Given this list of marker genes SERPINH1, PSAPL1, ANGPT2, UPP1, KRT15, MVK, STMN3, C1QBP, DOK2, GNGT2, FGF12, TGFB3 (NCBI Gene Id 7043), FBXO21, FOXA3, SYNPO, NCAPH2, LIPC, DEF8, GPR137B, RNF19B, ZBTB14, SAP30, A2M, DCK (deoxycytidine kinase), FEZ1, ATF6, SGO1, IMP4 (NCBI Gene Id 92856), PDZK1, DBT, RAB23, EVL, SYNE4, NR4A2, PSMD3, CD52, IKZF1, ADSS1, NOS2, SORD (sorbitol dehydrogenase), DNMT3A, DAGLB, UNC50, CSF3, RAD23B, GNL1, MELTF, PRRC1, TBRG4, IRF7, MRPS18B, CEP89, GSG1, PGD, KRT20, H2BC5, GALNT2, PPP2R5A, PDIA3, RRP1B, CIPC, KAT7, RBL1, MMP16, CYTIP, LIPE, TNFRSF11B, ELAC2, MORF4L2, ARPP19, EYA2, IKBKE, MTOR, CTSE, FOLR2, KCNA4, FCGR1A, WT1, CNGA1, PTGER1, RTL6, RMND1, ADAM8, TSR1, ALCAM, ITPK1, RNF123, AOAH (acyloxyacyl hydrolase), IER2, HMX1, CAPZB, PTGFR, RXRG, IGLC1, CDKN1C, PTPN9, CELSR2, TAGLN (transgelin), C3AR1, CRYL1, HSP90AA1, DKK3, ZBTB12, DNASE1L3 (deoxyribonuclease 1L3), PHF7, ACTG2 (NCBI Gene Id 72), IQGAP3, UCK1, RDH5, PLA2G1B, DNAAF10, MYBL2, ALDH18A1, SNRPB2, ODC1, RGCC, UBAP1, RAB21, CRISP2, MX2, BHMT2, CD44, PIM3, ARNT, BAAT, SYNGR2, LY9, APRT, SNRPD3, CCN2, ZIK1, ST6GALNAC4, NOP16, HSD3B2, NEFL, NRTN, SLC39A7, KRT32, TEAD1, BCAP31, HYOU1, TLR7, OLFM1, APBB1IP, B9D1, PGF, E2F3, LMAN1, MAT1A, TMEM176A, SNX12, CD80, NDP, RGS16, JUP, COPZ2, ZNF131, FHL2, DTX1, MYH10, RPRM, GNAS-AS1, AQR, LEP, TAPBP, LCK, FASTK, CHRNG, WNT3, RTN1, TERF2IP, IFNA1, KCNA3, RBM4B, KRT36, PCBP4, ELL2, PIK3R1, LHX3, CTSW, GC, CD72, SYN2, RAB8B (NCBI Gene Id 51762, RAB8B, member RAS oncogene family), POSTN, NECAP2, MAL, BGN, CBX5, TUBA1C, TMEM259, CDC23, HAND1, MCFD2 (NCBI Gene Id 90411), FOXA2, CYP4V2, TMEM129, OPN1LW, CAVIN1, XRN1, here is a description of the gene set: Human Gene Set: GSE43955_TGFB_IL6_VS_TGFB_IL6_IL23_TH17_ACT_CD4_TCELL_60H_DN from publication Yosef N, Shalek AK, Gaublomme JT, Jin H, Lee Y, Awasthi A, Wu C, Karwacz K, Xiao S, Jorgolli M, Gennert D, Satija R, Shakya A, Lu DY, Trombetta JJ, Pillai MR, Ratcliffe PJ, Coleman ML, Bix M, Tantin D, Park H, Kuchroo VK, Regev A (PMID 23467089) Despite their enormous importance, the molecular circuits that control the differentiation of Th17 cells remain largely unknown. Recent studies have reconstructed regulatory networks in mammalian cells, but have focused on short-term responses and relied on perturbation approaches that cannot be applied to primary T cells. Here, we develop a systematic strategy – combining transcriptional profiling at high temporal resolution, novel computational algorithms, and innovative nanowire-based tools for performing gene perturbations in primary T cells – to derive and experimentally validate a temporal model of the dynamic regulatory network that controls Th17 differentiation. The network is arranged into two self-reinforcing and mutually antagonistic modules that either suppress or promote Th17 differentiation. The two modules contain 12 novel regulators with no previous implication in Th17 differentiation, which may be essential to maintain the appropriate balance of Th17 and other CD4+ T cell subsets. Overall, our study identifies and validates 39 regulatory factors that are embedded within a comprehensive temporal network and identifies novel drug targets and organizational principles for the differentiation of Th17 cells. Genes down-regulated in CD4 T helper cells Th17 (60h): TGFB1 and IL6 versus TGFB1, IL6 and IL-23. species: Homo sapiens